The following is a description of a gene set: The process in which the structure and material content of mature peripheral nervous system myelin is kept in a functional state. species: Homo sapiens Human Gene Set: GOBP_PERIPHERAL_NERVOUS_SYSTEM_MYELIN_MAINTENANCE, and this is the list of marker genes: NDRG1, AKT2 (NCBI Gene Id 208), SH3TC2, SOD1, PRX (periaxin), FA2H, PLEC, PALS1, AKT1